The following is a description of a gene set: Any process that results in a change in state or activity of a cell or an organism (in terms of movement, secretion, enzyme production, gene expression, etc.) as a result of a gamma radiation stimulus. Gamma radiation is a form of electromagnetic radiation (EMR) or light emission of a specific frequency produced from sub-atomic particle interaction, such as electron-positron annihilation and radioactive decay. Gamma rays are generally characterized as EMR having the highest frequency and energy, and also the shortest wavelength, within the electromagnetic radiation spectrum. Mouse Gene Set: GOBP_RESPONSE_TO_GAMMA_RADIATION studied in species Mus musculus, and this is the list of marker genes: Prkdc, Lig4, Brca2, Xrcc6, Wrn, Mdm2, Ercc6, Ptprc, Fancd2, H2ax, Ddias, Tmem109, Elk1, Ccl7, Xrcc2, Pml, Gata3, Ccl2, Atm, Bak1 (BCL2-antagonist/killer 1), Tlk2, Cdkn2a, Yap1, Atr, Bcl2l1, Map3k20, Sod2, Bmyc, Trp53, Zmpste24, Cryab, Egr1, Xrcc4, Hsf1, H2aj, Chek2, Men1, Xrcc5, Hras, Polb, Gpx1, Il1a, Rad51 (NCBI Gene Id 99282), Apobec1, Gtf2h5, Prkaa1, Cbl, Myc, Pnp, Kdm1a, Tigar, Cdkn1a, Dcun1d3, Rnf4, Tspyl5, Cxcl2, Rpl26, Bcl2, Bax, Trex1